The following is a description of a gene set: A cell cycle process by which the cell nucleus divides as part of a meiotic cell cycle in the female germline. Mouse Gene Set: GOBP_FEMALE_MEIOTIC_NUCLEAR_DIVISION studied in species Mus musculus, and this is the list of marker genes: Ndc80, Hsf2bp, Sycp2, Sycp3, Pten, Rbm46, Trim75, Meikin, Ccnb2, Washc1, Aurka, Meioc, Dazl, Mei1, Cenpe, Fmn2, Spire1, Dcaf13, Ubb, Spin1, Mlh3, Orc4, Fbxo5, Top2a, Wee2, Ska2, Septin1, Ttk (NCBI Gene Id 22137), Sgo2a, Mlh1, Marf1, Atm (ataxia telangiectasia mutated), Hsf1, Plk1, Trip13, Ppp2r1a, Ska3, Brme1, Cdc25b, Meiob, Ska1, Ncaph, Ddb1, Washc5, Spire2, Mastl, Ncaph2, Ereg